The following is a description of a gene set: Any process involved in the activation of any of the steps of the classical pathway of the complement cascade which allows for the direct killing of microbes, the disposal of immune complexes, and the regulation of other immune processes. species: Mus musculus Mouse Gene Set: GOBP_COMPLEMENT_ACTIVATION_CLASSICAL_PATHWAY, and this is the list of marker genes: C1s2, Cr2 (complement receptor 2), Susd4, C4bp, Mbl1, C1qc, Hc, Cd55b, C1rb, C3, C1s1, Cr1l, Mbl2, Ighg2b, Igha, Cd55, C4b, Ighg3, Cfi, C1ra, C1qb, C8b (complement component 8, beta polypeptide), Trem2, C1qbp, C9, Masp2, Ighg1, Cd46, Crp, Ighg2c, C1qa, Serping1 (NCBI Gene Id 12258), Zp3r, C8g, C1rl, Ighe, Ighm, C2, C8a